The following is a description of a gene set: part of: Hedgehog 'on' state Reactome Pathway: GLI proteins bind promoters of Hh responsive genes to promote transcription GLI proteins are bifunctional DNA-binding proteins that recognize consensus GLI sites 5'-GACCACCC-3' in the promoters of target genes. Pathway induction upon ligand-binding diverts the GLI proteins from the processing/degradation pathway that generates the truncated repressor form and promotes the formation of the full-length transcriptional activator. GLI-dependent target genes have been identified by a number of ChIP based screens, and well-established, direct targets include a number of Hh pathway members including PTCH1, PTCH2, GLI1, HHIP and BOC. Full-length GLI proteins nucleate the assembly of a transcriptional activation complex at target gene promoters, but the details of interacting partners are not well known. The C-terminus of GLI3 has been shown to interact with a number of transcriptional activators including the histone acetyltransferase CBP, the Mediator component Med12 and the TATA-box recognition protein TAF31, but the detail of how and when these binding partners interact is not known. Each of the GLI proteins has been shown to bind to CDC 73, a component of the PAF complex that has roles in RNA polymerase II-mediated transcription. studied in species Homo sapiens, and this is the list of marker genes: GLI1, GLI3, HHIP, PTCH2, BOC, GLI2, PTCH1